The following is a description of a gene set: Renal insufficiency Human Gene Set: HP_RENAL_INSUFFICIENCY A reduction in the level of performance of the kidneys in areas of function comprising the concentration of urine, removal of wastes, the maintenance of electrolyte balance, homeostasis of blood pressure, and calcium metabolism. species: Homo sapiens, and this is the list of marker genes: ANKFY1, GLIS2, CAV1, WDR19, OSGEP, ACBD6, DHDDS, CLDN10, IFNG, ARHGAP24, IL10 (NCBI Gene Id 3586), RAD51, GTF2I, ITGA3, KARS1, DNAJC30, NFS1, STOX1, CTLA4, PEX7, RPGRIP1L, ANLN, FANCG, SLC4A2, ERCC8, AVPR2, PKD1, REN, GCM2, NPHP1, ZNF592, IFT43, IFT80, SLC5A1, CD81, NDUFAF6, RRM2B (NCBI Gene Id 50484), RNU7-1, PGAM2, FANCD2, GLA, SCLT1, CSPP1, ZNF699, TBX18, CCN2, PALB2 (NCBI Gene Id 79728), TLR4, GAPVD1 (NCBI Gene Id 26130), LIMK1, BBS1, CLDN16, ALOX12B, NTRK1, IFT27 (NCBI Gene Id 11020), HLA-DPA1, CC2D2A, BNC2, GCDH, DAAM2, TBX1, LPIN1, EIF2AK3, ALMS1, HNF1B, WT1, MOCOS, STS, MEN1, NPHS2, ASL, FANCF, FAH, TPRKB, DGKE, LYZ, DYNC2LI1, DZIP1L, NUP107, PAX2, GSN, BBS2, CFB, AP2S1, NCF1, ROBO1, COL7A1, RFC2, EBF3, MED12, STAT2, ZNFX1, SLX4, PRDX1, PTPN22, LAMA5, NIPBL, SCNN1B, TRPC6, CHRM3, CPT2, TTC8, FANCL, SEC61A1, MAGI2, MEFV, PAX6, PUS3, TSC1, HBB, HDAC8, TMEM126B, SLC7A7 (NCBI Gene Id 9056), DYNC2I2, FANCA, CUBN, DYNC2H1, DCDC2, PTPRO, TMEM231, ABCA12, WDR73, SARS2 (seryl-tRNA synthetase 2, mitochondrial), NIPAL4, RMND1, MT-CO1, JAG1, CLPB, MLXIPL, BAZ1B, ELP1, SOX18 (NCBI Gene Id 54345), TMEM237, SMC3, KCNE5, NUP160 (NCBI Gene Id 80116), MKKS, YRDC, COL4A4, MDM2, BBS10, WDR35, APRT, SHPK, TBC1D8B, UBE2T, CCNQ, NUP133, BBS12, CORIN, ANKS6, ALDOA, MAPKBP1, PRPS1, CFHR5, LRIG2, BUD23, FANCM, SH2B1, IFNGR1 (interferon gamma receptor 1), BBS7, COL4A6, LAMB2, CLCNKA, HELLPAR, PRKCD, CFI, KDM6A, CEP120, CD2AP, CRB2, NPHP3, HPRT1, MYOCD, VPS37D, PBX1, FN1, IL12A, CD151, PKHD1, CCR6, SLC3A1, SPRY2, GON7, TCN2, AP1S3 (adaptor related protein complex 1 subunit sigma 3), KCTD1, MAD2L2, EHMT1, ASPRV1, SCNN1G, LMX1B, SMARCAL1, JAK2, CCND1, SDR9C7, CEP83, MME, MYO1E, INVS (inversin), FANCE (FA complementation group E), GRHPR, FUZ, NPHP4, BBS4, AQP2, IL12A-AS1, CEP164, CACNA1S, HPSE2, MT-CO3, THBD, PYGM, OCRL, XRCC2, CHD4, SLC41A1, LAGE3, STAT4, SCARB2, CALR, DACT1, ELN, PGK1, MT-ATP8, CHRNA3, DNAJB11, SALL1, RYR1, CEP290, COL4A3, CLDN19, PLCE1, SLC7A9, IFT172, GTF2IRD1, RAD51C, CLCNKB, TMEM260 (NCBI Gene Id 54916), CCR1, FAM20A, C4A, SLC26A1, SAT1, P4HA2, KYNU, TBL2, SULT2B1, PKDCC, SIX1, EIF4H, APOA1, IQCB1, MKS1, ARL6, IRAK1, NEK8, DSTYK, NUP205, F5, MMUT, CFHR1, MST1, AHI1, SLC2A9, BTNL2, MMACHC (NCBI Gene Id 25974), CFHR3, CD46, SLC30A9, HNRNPK, ALDOB, LCAT, LZTFL1, TRIM32, HPS1, ALG1, FXYD2, NOTCH2, GATM, SDCCAG8 (SHH signaling and ciliogenesis regulator SDCCAG8), SCNN1A, SCAPER (NCBI Gene Id 92909), APOE, PHYH, CFAP418, TGM1, INF2, MUC1, NUP85, IFT122, ACTN4, INPP5E, GPR35, METTL27, ZMPSTE24, XIAP, CLCN5, XPNPEP3, FASLG, PNPLA6, PPOX (protoporphyrinogen oxidase), SIX5, COL4A5, AGXT, SPP1, CDC73, SLC34A1, HOXA13, MYD88, CASP10, PKD2, TMEM216, SLC37A4, BRCA2, CFH, HLA-B, DNASE1L3, CTNS, TTC21B, TCF4, CEP19, BICC1, LDHA, FANCB, IL36RN (NCBI Gene Id 26525), SAA1, KIAA0586 (NCBI Gene Id 9786), HSD11B2, RFWD3, CLIP2, PIGA, CYP4F22, APOL1, ERCC4, KIAA0753, TMEM270 (transmembrane protein 270), ERAP1, UBAC2, BBIP1, SLC22A12, COG1, IRF5, TMEM138, PRTN3, ZNF423, MAFB, NOS1AP, BRIP1, EHHADH, OBSCN, AMN, KMT2D, IFT140, HMBS, BRCA1, UMOD, TSC2, IKZF1, MMP1, STX1A, SEMA4D, IFT74, NSD1, HLA-DRB1, COQ6 (NCBI Gene Id 51004), VANGL1, RAD21, LIPN, GANAB, ERCC6, GTF2IRD2, ALG5, AVIL (NCBI Gene Id 80056), BRD4 (bromodomain containing 4), ALDH4A1 (NCBI Gene Id 8659), EYA1, HLA-DPB1, FLT1 (fms related receptor tyrosine kinase 1), FKBP6, OFD1, EMP2, HRAS, FAN1, TRAF3IP1, POLRMT, IFT56, ALG9, SGPL1, NUP93, KLRC4, MT-TL1, SRCAP, ACP5, DYNC2I1, IL23R, OCLN, ARHGDIA, APC2, C3, LHX1, MT-TT, TMEM67, FANCC, TAF6, WDPCP, BBS5, BSND, GATA3, COQ8B, NLRP3, ACSL4, AMMECR1, ALOXE3 (arachidonate epidermal lipoxygenase 3), SMC1A, NOD2, NUP37, TP53RK, COL4A1, FANCI (NCBI Gene Id 751608), FAS, NPHS1, MYCN, B2M, BBS9, MYH9